The following is a description of a gene set: part of: SLC transporter disorders Reactome Pathway: Defective SLC12A6 causes agenesis of the corpus callosum, with peripheral neuropathy (ACCPN) studied in species Homo sapiens K+/Cl- cotransport is implicated not only in regulatory volume decrease, but also in transepithelial salt absorption, renal K+ secretion, myocardial K+ loss during ischemia and regulation of neuronal Cl- concentration. Four genes (SLC12A4-7) encode the K+/Cl- cotransporters KCC1-4 respectively. Cotransport of K+ and Cl- is electroneutral with a 1:1 stoichiometry. These cotransporters function as homomultimers or heteromultimers with other K+/Cl- cotransporters. SLC12A6 encodes KCC3 which is highly expressed in heart, brain, spinal cord, kidney, muscle, pancreas and placenta. Defects in SLC12A6 are a cause of agenesis of the corpus callosum with peripheral neuropathy (ACCPN; MIM:218000), a autosomal recessive disease characterised by severe progressive sensorimotor neuropathy, mental retardation, dysmorphic features and variable degree of agenesis of the corpus callosum., and this is the list of marker genes: SLC12A6